Given this list of marker genes DNAJC14, CSRNP2, HIGD1AP9, ENSG00000299062, OR6C6, SHMT2, DDIT3, STAC3, PDE1B, KRT77, TMT1A, ARL2BPP2, CCDC184, MARS1, PCBP2-OT1, KRT79, NEUROD4, DTX3, HOXC13-AS, TAMALIN, ESYT1, PA2G4, SLC48A1 (NCBI Gene Id 55652), PCBP2 (NCBI Gene Id 5094), OR9R1P, CALCOCO1, PCED1B-AS1, DDN, KRT1, HOXC10, SDR9C7, GSTP1P1, KRT128P, HOXC-AS3, ITGA7, OR5BS1P, HNRNPA1, RARG, CNPY2-AS1, MIR6758, PHB1P19, OR6C65, RNU6-238P, TROAP, KRT3, ADCY6-DT, FAM186B, SNORA2A, GPR182, CNPY2, OR6C68, ORMDL2, ZNF385A, ARF3, GLYCAM1, ENSG00000298361, PRIM1, MIR3198-2, MYO1A, C1QL4, KRT6B, KRT81, ANKRD52, KRT7, SLC11A2, MYL6B-AS1, HOXC5, GTSF1, PRR13, ENSG00000309140, OR9K2, SMARCC2, CISTR, COQ10A, TFCP2, OR6C5P, APOF, PSMB3P1, KRT8, MIR1293, HOXC12, FAM242C, ITGB7, KRT71, ENSG00000212383, ACVR1B, SP7, TMT1AP1, FAIM2, LINC02381, R3HDM2 (R3H domain containing 2), APONP, LACRT, ZNF641, NCKAP5L, HOXC6, CDK2, ENSG00000257550, LINC02416, OR7A19P, ANP32D, ESPL1, HIGD1AP1, ATP5F1B, LINC00592, OS9, PCED1B, RPS26, KRT88P, RN7SL390P, TUBA1C (NCBI Gene Id 84790), KRT82, RDH16, PRPF40B, OR10AD1, LIMA1, SARNP, RNU7-40P, ADI1P3, KRT125P, RND1, GPR84 (NCBI Gene Id 57098), RAB5B, TUBA1B-AS1, WNT10B, SCN8A, ENSG00000285133, RNU6-1093P, OR2AP1, GPD1, ACVRL1, SMUG1, HNRNPA3P10, OR9K1P, CCNT1, STBD1P1, OR6C70, RN7SKP289, LARP4, KRT85, SLC26A10P, GLS2, OR10U1P, SLC4A8-AS1, KMT2D, RN7SL744P, PFDN5, ATF7-NPFF, ENSG00000286069, KRT80, CD63-AS1, KRT5, OR5BJ1P, TMDD1, ERBB3, NABP2, FIGNL2-DT, BTBD10P1 (NCBI Gene Id 100128678), RNF41, BLOC1S1, KRT86, DNAJC22, ADCY6 (NCBI Gene Id 23320), LRP1-AS, FMNL3, KRT78, AQP2, ATP5MC2, MIR148B, HOXC8, SP1, ZBTB39, CCDC65, ENSG00000199566, ENSG00000283536, ENSG00000299015, SPRYD3, DIP2B, MYG1-AS1, SNORA2C, PMEL, IGFBP6, WNT1 (Wnt family member 1), NPFF, KCNH3 (NCBI Gene Id 23416), LINC02396, STAT6, SLC39A5, LSM6P2, RPAP3, SUOX, RNU6-834P, CELA1, KRT18, ENSG00000248576, OR6C3, HOXC11, DGKA, OR6U2P, NDUFA4L2, OR10P1, RPL13AP21, RNU6-199P, AAAS (NCBI Gene Id 8086), NFE2, OR7E47P (NCBI Gene Id 26628), GPR84-AS1, DCTN2, KRT4, PHC1P1, ENSG00000258763, TMEM106C, HOXC-AS1, MIR1291, DCD (dermcidin), MCRS1, LRP1, MIR6505, OLA1P3, AMHR2, COX14, PARK7P1, RPL31P51, HOXC9, ATP6V1FP2, DAZAP2 (NCBI Gene Id 9802), RNU6-574P, RPS10P20, LINC02874, EIF4B, RNU6-879P, SPATS2, KRT89P, MIR196A2, KRT84, OR6C64P, B4GALNT1, OR11M1P, NR4A1AS, MAP3K12, GDF11, RNU6-1273P, RPL35AP28, KRT126P, PRKAG1, HOXC13 (NCBI Gene Id 3229), NXPH4, IKZF4, MIR4701, OR5BK1P, OR10A7, COL2A1, MYL6B (NCBI Gene Id 140465), HSPD1P4, LINC02395, KRT2, OR6C1, MUCL1, CBX5, ZNF740, RPL41, RPL32P27, SNORA2B, DHH, HDAC7, OR8S21P, ENSG00000303687, PRPH, ATF7, LETMD1, HIGD1C, MIR6757, COPZ1, RPL7P41, NR4A1, VDR, IFITM3P6 (IFITM3P pseudogene 6), RNU6-769P, MBD6, PAN2, MFSD5 (major facilitator superfamily domain containing 5, NCBI Gene Id 84975), GALNT6, KRT90P, ITGA5, OR6C71P, SPMIP11, ENSG00000257989, SNORD59A, KRT74, TAC3, KRT87P, TROAP-AS1, PTGES3, OR6C76, VTI1BP3, BCDIN3D-AS1, RNU6-950P, RHEBL1, KRT127P, BAZ2A, RPL35AP29, SCAT2 (NCBI Gene Id 112935960), RPAP3-DT, TMT1B, SMAGP, GLI1, MMP19, KRT6A, NAB2, KRT72, OR6C73P, POU6F1, OR5BT1P, ENDOU, MIR616, BCDIN3D, OR8T1P, AMIGO2, RN7SL809P, OR8S1, PIP4K2C, MIP, TARBP2, SLC38A4, PPP1R1A, R3HDM2-DT, TMEM198B, PFKM, RDH5, RNU6-87P, ENSG00000257346, AQP5, FKBP11, AQP5-AS1, SMARCD1, CSAD, MYL6, MIR615, KRT73-AS1, TNS2, BIN2, VDAC1P5, CS, NEMP1, POLR2KP1, RNU6-1203P (NCBI Gene Id 106480092), KRT7-AS, SPRYD4, PHB1P18, HOXC4, RN7SL519P, LMBR1L, KRT73, TMPRSS12, HSD17B6, OR10AE3P, SENP1, EIF4A1P4, RNU6-940P (NCBI Gene Id 106479982), IL23A, RAPGEF3, NACA, SLC38A2-AS1, FAM186A, LINC02354, RBMS2, C12orf54, LINC02156, KRT83, TNS2-AS1, AQP6, FLJ12825, PYM1, ATG101, HOTAIR, MARK3P1, ATF1, H1-7, MYG1, KANSL2, OR6C2, SLC38A2, OR6C75, MIR4698 (NCBI Gene Id 100616486), OR6C74, TIMELESS, TUBA1B, HOXC-AS2, CACNB3, OR6C66P, OR6C7P, ANKRD33, MIR1228, SMIM41, DDN-AS1, RNU6-343P, PPIAP45, STAT2, RNU6-333P, ZC3H10 (zinc finger CCCH-type containing 10), NCKAP1L (NCK associated protein 1 like), KRT75, ASIC1, KRT6C, OR6C72P, DDX23, ASB8, RACGAP1, FIGNL2, LALBA, KRT76, INHBC, SLC4A8, OR6C69P, OR6C4, RNU6-600P, SLC38A1, SOAT2, KIF5A, TUBA1A, TESPA1, RPL13AP23, CD63, MIR4494, ARHGAP9, SLC38A4-AS1, INHBE, ARHGEF25, ENSG00000301788, CERS5, TMBIM6, here is a description of the gene set: Human Gene Set: chr12q13 studied in species Homo sapiens